The following is a description of a gene set: species: Homo sapiens Reduced intensity (volume) of speech. Weak voice Human Gene Set: HP_WEAK_VOICE, and this is the list of marker genes: DNAJC6, TRIM37, GBA1, ATXN3, DCTN1, ATXN8OS, MAPT, NR4A2, FTL, SLC52A3, MT-TT, ATP6AP2, AOPEP, TBP, COQ6, TONSL, SNCAIP, LZTR1, MATR3, ADH1C, HSPG2, SYNJ1, FHL1, NF2, SYT2, ATXN2, SMARCB1, GARS1, PODXL, TK2, POLG